The following is a description of a gene set: studied in species Homo sapiens Genes having at least one occurrence of the motif NCNNTNNTGCRTGANNNN in the regions spanning 4 kb centered on their transcription starting sites. This matches the PAX8 transcription factor binding site V$PAX8_B (v7.4 TRANSFAC). Human Gene Set: PAX8_B, and this is the list of marker genes: PAPPA, PDZD7, CAMK1D, CFAP20, NABP2, EML1, POU4F3, AHCYL1, MNT, TMEM255A, MAP2K5, OSBPL7, ARB2A, MYF5, NEUROG1, LUC7L3, TMTC2, WNT4, HOXB4, DNAI1, METTL26, PURA, PUM2, TRERF1, CALD1, TSPAN2, SRPK2, GABRA1, BHLHE22, RHOBTB1, LRRC74A, PIK3R3, TIA1, NOL4, FAM219A, CCDC24, ZNF385B, SH3GL3, HNRNPA0, HOXB7, MAN1C1, NRG1, JMJD1C, GARIN1B, IARS1, NRGN, RNF220, HR, ALCAM, DIO2, TWIST1, SUPT16H, OLFM2, RERG (RAS like estrogen regulated growth inhibitor), KLHL13, PPP2R2B, CNTN6, ABLIM3, TSHZ2, NECAB3, HOXB5, ATP1B4, BEND4, RBM39, TAF5, ELMO3, GGN, GPR27, GPC4, LRMDA, PPM1A, HOXB8, GABRG2, MYBPC1, SP6, DLG2, NEUROD6, HOXD12, BDNF, RHOQ, BNC2, KCNQ1DN, TCF7L2, TEK, RGS12, ACTN1 (actinin alpha 1), PTCH1, HPN, CLTC, PAK1IP1, MYO18A, ELK4, IGSF22, HOXD8, TANK, MARCHF1, RARB, HIVEP1, LHFPL1 (NCBI Gene Id 340596), HOXA9, ATP5MC1, NR1D1, NPM3, RELCH (NCBI Gene Id 57614), SLC25A28, FEZF2